Given this list of marker genes USP46, BHLHE40, KLK15, PURB, CCDC174, HOXA4, CYLC1, LIN54, EFEMP1, PSMB1, STKLD1, GABRA5, RICTOR, SPPL3, INSM2, KLHL2, RANBP1, GTF2A1, NUP42, ADAM9, HOXB7, PFAS, XPO4, MOB1B, LMTK3 (lemur tyrosine kinase 3), FOXO1, CCER1, KIAA1549L, DLST, ABT1, ASIC2, H2BC18, PHF20L1, FUNDC2, SEL1L, DAG1, RABGAP1L, RNPC3 (RNA binding region (RNP1, RRM) containing 3), UST, CNOT2, CBLL2, FGF13, TOP2B, BCL2L11, CDH8, FBXO4, HOXD10, ARID2, HMG20A, EIF1AD, GPR171, SH3TC2, ELK3, USP49, GLE1, FAM120C, GK5, CCN2, NAMPT, TCAF1 (TRPM8 channel associated factor 1), MON2, KLF11, AMD1, MYT1L, CREBRF, MICU3, FUCA1, PEX5, NLGN4Y, EEF1E1, VKORC1L1, GTF3C3, PDE4B, CREBBP, RLF, PIP4P1, DNAJC14, DTD1, PRTG, EI24, YES1 (YES proto-oncogene 1, Src family tyrosine kinase), CDK19, RNF152, MYORG, NUS1, DRAM1, TFB1M, YIPF6, HNRNPU, POSTN, GRK5, OLFM4, PLK2, STX5, CCL4L2, IL15, CPS1, CAMTA1, FAHD1, RAB3C, SSRP1, HTR4, DOK6, DOCK9, SRGAP2, RPA3, AGGF1, CDH18, HVCN1, ZC4H2, UBL3, here is a description of the gene set: Genes predicted to be targets of miRBase v22 microRNA hsa-miR-584-3p in miRDB v6.0 with MirTarget v4 prediction scores > 80 (high confidence targets). Human Gene Set: MIR584_3P from publication Chen Y, Wang X (PMID 31504780) species: Homo sapiens